The following is a description of a gene set: Effects of IL-4 on CD8 T cells functions are largely unknown. IL-4 induces survival and proliferation of CD8 T cells, but several studies suggest that IL-4 could also affect several functions of CD8 T cells such as cytotoxicity. Our team has shown that IL-4 repress the expression of Ccl5 in vitro. To define more precisely the impact of IL-4 on CD8 T cells, we performed a whole genome expression microarray analysis of naive and memory CD8 T cells cultured in presence or absence of IL-4. This approach allowed us to define the IL4-gene-expression signature on CD8 T cells. studied in species Homo sapiens Human Gene Set: GSE32423_MEMORY_VS_NAIVE_CD8_TCELL_IL7_DN Genes down-regulated in comparison of memory CD8 T cells treated with IL7 versus naive CD8 T cells treated with IL7. from publication Ventre E, Brinza L, Schicklin S, Mafille J, Coupet CA, Marçais A, Djebali S, Jubin V, Walzer T, Marvel J (PMID 22942430), and this is the list of marker genes: AMN, PDZD4, SHQ1, NOP16, RIOX2, RRAGD, IL4R, BATF3, TNFRSF18, CFAP20DC, SALL2, KAT14, JUNB, GPRIN1, TRIT1, ALDH9A1, USP10, SYN3 (synapsin III), PEBP1, TMEM41B (NCBI Gene Id 440026), MRPS18B, QDPR, CHKA, APIP, HEMGN, COP1, APEX1, LARP1, KANK3, THOC3, RNF185, TUBB2B, PRDM4, EHD4, PLCD1, HMGA1, MAP3K11, TRAPPC9, SLC44A1, LAP3 (leucine aminopeptidase 3), GTSF1L, SGSM2, RBP1, ORAI1, ATP5PO, MARCKS, NABP1, SLC16A2, HEATR1, MBD5, SPEF1, NUP62, C4B, SH2D6, HDAC3 (NCBI Gene Id 8841), NEK1, SYMPK, HCFC2, BNIPL, NKD1, ARMCX4, CCDC184, SGTA, CEP85, RNF169, PWP1, PLSCR3, GPBP1L1, PPP1R3B, PCSK4, EIF4G1, SULT1B1, BORCS6, NDUFAF1, PWP2 (NCBI Gene Id 5822), PABPC4, ABHD8, CTPS1, NAT10, ZNF205, NMT1, SAR1A, FASTKD1, KLF10, SLC10A3, PHF5A, PUS7, EXOSC2, DENR, CAP2, LFNG, STX2, GLCE, PLPP1, UCK2, PEPD, RPL28, SWSAP1, DOCK1, RRP12, TRAPPC6A, MTHFD1L, THAP11, EPHX1, RABGAP1, IDO2, TRIM28, NUP188, RORC, SUV39H1, PPRC1 (NCBI Gene Id 23082), PRPF31, MTAP, TMCC3, CAPS2, DVL2, SLC31A1, FXN, API5, SHF, KLHL11, HMGXB4, LRPPRC, AMIGO2, TMEM97, TEX30, TCP1, GRWD1, ACADSB, MTHFD1, RALB, PAOX, PRKAR2B, MTFP1, SLC16A10 (solute carrier family 16 member 10), TSACC, YDJC, FXR2, PSMD14, NDOR1, KIF23, SEMA3A, GIPC1, SUOX, UPF1, CALML5, TFAP2E, WDR43, PNPO, RTCB, KRTAP26-1, PCNX1, MEF2D, WDR82, DGCR2, BRD2, SPC24, TMEM41A, EEIG1, POLR1B, EBAG9, BRI3BP, NANP, RRP7A, SRRM4, MRS2, VAPB, FRMD6, BAZ2B, PEX3, SOBP, FAM83E, CAPN15, GUK1, EMC6, UNK, PAPOLA, ZNF830, BAG2, CYP27B1, RMDN3 (NCBI Gene Id 55177), RARS1, RHBDL1, SLC35A4, KDSR (NCBI Gene Id 2531), SORD, METTL25 (NCBI Gene Id 84190), ATP5F1D, GID4, PIM3, KTI12, ZBTB11-AS1, POMC, DMKN, PRKAB2, LRRC47, ID1, NME1, DET1, SPC25